Given this list of marker genes Nr4a3, Tbx3, Eya1, Zeb1, Hoxa1, Gli3, Rubie, Sparc, Fgf10, Gata2, Tbx1, Fgf3, Chd7, here is a description of the gene set: The progression of the semicircular canal from its initial formation to the mature structure. species: Mus musculus Mouse Gene Set: GOBP_SEMICIRCULAR_CANAL_DEVELOPMENT